Given this list of marker genes IGHM, LRRC8A, ATM, RAG1, LAPTM5, RAG2 (NCBI Gene Id 5897), here is a description of the gene set: species: Homo sapiens The process in which a precursor cell type acquires the specialized features of a pre-B cell. Pre-B cells follow the pro-B cell stage of immature B cell differentiation and undergo rearrangement of heavy chain V, D, and J gene segments. Human Gene Set: GOBP_PRE_B_CELL_DIFFERENTIATION